The following is a description of a gene set: Human Gene Set: chr12q15 studied in species Homo sapiens, and this is the list of marker genes: LINC02421, IL22, FAHD2P1, PTPRR, MYRFL, SNORA70G, RNU7-4P, LINC02373, CCT2, LRRC10, PRANCR, RPL39P28, LINC02821, CNOT2, LINC02420, RN7SL804P, RPL10P12, RPL7P42, ATP5PDP4, LYZ, MDM2, HNRNPA1P70, KCNMB4, YEATS4, NUP107-DT, CPSF6, NTAN1P3, MIR1279, LINC02384 (NCBI Gene Id 101927981), IFNG, MIR3913-2, BEST3, RPS26P45, MRPL40P1, MIR3913-1, LINC02442, SZRD1P1, NUP107, KRT8P39, IFNG-AS1, SLC35E3, MDM1, CPM, PRELID2P1, RNU4-65P, RAP1B, DYRK2, RPSAP12, PTPRB, LINC02408, ENSG00000258168, IL26, FRS2, ENSG00000247131, RAB3IP, C1GALT1P1, LINC01479